The following is a description of a gene set: Non-small cell lung carcinoma Human Gene Set: HP_NON_SMALL_CELL_LUNG_CARCINOMA studied in species Homo sapiens, and this is the list of marker genes: FASLG, SPRED1, KRAS, CASP8, TP53, ZNRF3, PPP2R1B, ERCC6, CDKN2A, SLC22A18, PIK3CA, BAP1, PRKN, PRKAR1A, EGFR, MAP3K8, TERT, BRAF, CYP2A6, NDUFAF6, ERBB2, CTNNB1, IRF1